The following is a description of a gene set: Reactome Pathway: Protein repair part of: Metabolism of proteins This event has been computationally inferred from an event that has been demonstrated in another species.<p>The inference is based on the homology mapping from PANTHER. Briefly, reactions for which all involved PhysicalEntities (in input, output and catalyst) have a mapped orthologue/paralogue (for complexes at least 75% of components must have a mapping) are inferred to the other species. electronically inferred by orthology from the curated human pathway species: Mus musculus, and this is the list of marker genes: Msrb3, Txn1, Msrb2